Given this list of marker genes MIR144, MIR93 (microRNA 93), MIR758, MIR185, ADIPOQ, MIR148A, PLA2G10, MIR302A, APOE, APOC1, ABCA2, MIR9-1, APOC2, MIR301B, MIR33B, MIR27B, PCSK9, MIR26A1, NFKBIA, MAPK3, MIR27A (NCBI Gene Id 407018), MIR613, APOA2, EGF, SREBF2, MIR19B1, MIR17, SHH, MIR128-1, MIR130B, MIR206, MIR33A, APOC3, MIR145, here is a description of the gene set: studied in species Homo sapiens Human Gene Set: GOBP_NEGATIVE_REGULATION_OF_STEROL_TRANSPORT Any process that stops, prevents, or reduces the frequency, rate or extent of the directed movement of sterols into, out of or within a cell, or between cells, by means of some agent such as a transporter or pore.